Given this list of marker genes SPIRE2, SPIRE1, SNX9, SNX33, RHOA, AURKB, SNX18 (sorting nexin 18), here is a description of the gene set: Human Gene Set: GOBP_CLEAVAGE_FURROW_FORMATION studied in species Homo sapiens Generation of the cleavage furrow, a shallow groove in the cell surface near the old metaphase plate that marks the site of cytokinesis. This process includes the recruitment and localized activation of signals such as RhoA at the site of the future furrow to ensure that furrowing initiates at the correct site in the cell.